The following is a description of a gene set: species: Mus musculus from publication Chen Y, Wang X (PMID 31504780) Genes predicted to be targets of miRBase v22 microRNA mmu_miR_376a_5p in miRDB v6.0 with MirTarget v4 prediction scores > 80 (high confidence targets). Mouse Gene Set: MIR_376A_5P, and this is the list of marker genes: Tmem129, Serpinb5, Msantd4, Negr1, Nkain2, Krtap6-6, Cnst, Trim30b, Fbxl17 (F-box and leucine-rich repeat protein 17), Ift56, Capzb, Uri1, Chic1, Pak2, Asah1, Zfp808, Napepld, Cgrrf1, Gpr158, Cfi, Zfp934, Rerg, Hoxa9, Hrh2, Cand1, Pgr, Opcml, Phyhipl, Dgkb, Tm4sf20, Sc5d, Ndufs4, Gpr171, Pds5b, Brwd3 (bromodomain and WD repeat domain containing 3), Csn2, Gm5141, Or8g20, Slitrk6, Rag2, Brd1, Glrb, Epha7, Acvr1, Glt8d1, Zfp935, Tcf24, Kctd9 (NCBI Gene Id 212162), Rpain, Stk40, Dnase2b